The following is a description of a gene set: Hepatic graft versus host disease (GVHD), day 35: genes up-regulated in allogeneic vs syngeneic bone marrow transplant. Human Gene Set: ICHIBA_GRAFT_VERSUS_HOST_DISEASE_35D_UP studied in species Mus musculus from publication Ichiba T, Teshima T, Kuick R, Misek DE, Liu C, Takada Y, Maeda Y, Reddy P, Williams DL, Hanash SM, Ferrara JL (PMID 12663442) The liver, skin, and gastrointestinal tract are major target organs of acute graft-versus-host disease (GVHD), the major complication of allogeneic bone marrow transplantation (BMT). In order to gain a better understanding of acute GVHD in the liver, we compared the gene expression profiles of livers after experimental allogeneic and syngeneic BMT using oligonucleotide microarray. At 35 days after allogeneic BMT when hepatic GVHD was histologically evident, genes related to cellular effectors and acute-phase proteins were up-regulated, whereas genes largely related to metabolism and endocrine function were down-regulated. At day 7 after BMT before the development of histologic changes in the liver, interferon gamma (IFN-gamma)-inducible genes, major histocompatibility (MHC) class II molecules, and genes related to leukocyte trafficking had been up-regulated. Immunohistochemistry demonstrated that expression of IFN-gamma protein itself was increased in the spleen but not in hepatic tissue. These results suggest that the increased expression of genes associated with the attraction and activation of donor T cells induced by IFN-gamma early after BMT is important in the initiation of hepatic GVHD in this model and provide new potential molecular targets for early detection and intervention of acute GVHD., and this is the list of marker genes: HLA-DRB1, CHIA, PSMB9, PROM1, MSR1, LTF, LGMN, CASP1, GLTP, CTPS1, LPL, AIF1, GRN, CCR1, SERPINA3, MARVELD1, CD52, APBB1IP, CD7, PLD3, HLA-DMA, SPTLC2, QSOX1, CCL5, SMOC2, UBD, HLA-DQB1 (NCBI Gene Id 7924), TAPBP, PTPN1, TAP1, LCK, ATP1B3, SAMHD1, FCGR1A, CFP (NCBI Gene Id 5200), CD74, NCF4, CYBB, MT1F, PKM, LILRB1, SULT2A1, SIRPA, NOP2, CSF1R, C1QC, GDF5, NFKBIZ, CCL2, FPR1, IRGM, S100A4, S100A9, TRAF3IP2, VCAM1, LITAF, MCRS1, HLA-DMB, ITGB2, LGALS3, S100A6, RRAS, LYZ, RBM3, C1QB, TYROBP, TMSB4X, LCP2, TLR6, STX3, SCMH1, ADGRE1 (adhesion G protein-coupled receptor E1), CD68, PLAC8, RNASE3, SHISA5, PLD4, LBP, CCL4, SELPLG, COLGALT1, PDK3, CTSC, CYB561, S100A8, GBP2, RND2, IL18BP, ORM2, MPEG1, NAMPT, PTPRC (protein tyrosine phosphatase receptor type C), IFI16, SNX12, HLA-B, CYBA, LRG1, BIRC5, LAPTM5, TRBC2, TMSB10, CYTIP, CXCL9, TFF3, NNMT, BCL2A1, SCD, CD5L, FGL2, STAT1, HCK, CD14, CLIC1, BTG2, IQGAP1, C1QA, ORM1, PRTN3, CAMP (NCBI Gene Id 820), SH3GL1, CYP26A1, NABP1, PLK1, MMP12, NCOA3, MCM4, LILRA4, HPX, GPX3 (glutathione peroxidase 3), HLA-DQA2, SLFN12, PROCR, SLPI, TSPAN4, WARS1, MT1X, CD53, CTSS, S100A11, SNX10, DCLRE1A (DNA cross-link repair 1A)